The following is a description of a gene set: species: Homo sapiens Human Gene Set: GSE10239_MEMORY_VS_DAY4.5_EFF_CD8_TCELL_DN Genes down-regulated in comparison of memory CD8 T cells versus effector CD8 T cells. Using killer cell lectin-like receptor G1 as a marker to distinguish terminal effector cells from memory precursors, we found that despite their diverse cell fates both subsets possessed remarkably similar gene expression profiles and functioned as equally potent killer cells. However, only the memory precursors were capable of making IL-2 thus defining a novel effector cell that was cytotoxic, expressed granzyme B, and produced inflammatory cytokines in addition to IL-2. This effector population then differentiated into long-lived protective memory T cells capable of self-renewal and rapid re-call responses. Mechanistic studies showed that cells that continued to receive antigenic stimulation during the later stages of infection were more likely to become terminal effectors. Importantly, curtailing antigenic stimulation towards the tail-end of the acute infection enhanced the generation of memory cells. These studies support the decreasing potential model of memory differentiation and show that the duration of antigenic stimulation is a critical regulator of memory formation from publication Sarkar S, Kalia V, Haining WN, Konieczny BT, Subramaniam S, Ahmed R (PMID 18316415), and this is the list of marker genes: SET, ANKRD46, MARCHF5, KDM1B, YIPF5, PEX13, FARP1, MRPL44 (mitochondrial ribosomal protein L44), CASD1 (CAS1 domain containing 1), RRS1, DRAM2, LRBA, CSNK2A2, FAIM, ITPR1, RFC5, PRIM1, RPL23, MFF, DUSP4, PPM1H, SAP30, YTHDF2, TRIM59, SMARCC1, CTPS1, FLVCR1, AP3S1, CDK1, FDFT1, CDC16 (cell division cycle 16), XPO7, ACTR3, POGZ, MAPK9, DR1, BCL2L11, GSR, VKORC1L1, MORF4L2, DCUN1D5, MRPL39, NFYB (NCBI Gene Id 4801), KDSR, PRELID3B (PRELI domain containing 3B), BUB1B, C1GALT1, ERMARD, MEMO1, SSBP1, CRK, GTF2B, SLBP, GLRX3, WSB1, FEN1, NAA20 (N-alpha-acetyltransferase 20, NatB catalytic subunit), RPP30, METAP2, TCEANC, EAF1, PIGL, SLC39A6, CDCA5, MCM10, ASXL1, COPS5, GZMB, POU2AF1, AIFM1, ATL2, IBTK, CBX3, TAF3, SETD6, ALG10, IDH3A (NCBI Gene Id 3419), CYP20A1, SELENOI, VAPA, KCMF1, SLC35E2B, RFX5, KIF22, EED, GNA13, FRMD4B, HMGCR, NDUFAF5, TSTD2, HSD17B12, SLC25A4, CCDC34, FEM1B, LUC7L2, UBA2, SSR3, FBXW11, STRAP, SELENOH, NAA30, C1D, TP53BP1, GAPVD1, HARS1, RAPGEF2, TRA2B, NUDT5, MCM4, TUBB2A, SRSF10, CAND1, AP1S2, USP39, GINS2, OBI1, MCM2, SNRNP40, YAF2, SAV1, LDHA, GARS1, TAF5, KLHDC2, RSBN1, HMGCS1, UBP1, PRPF38A, LAMTOR3, USP42, ICOS, PRPS1, NARS1, EIF1AX, ZNF236, VAMP3, ZBTB14, PAFAH1B2, RBM7, MCM5, UFSP2, AHCYL2, RAB14, VMA21, PDLIM5, TYMS, GRSF1, PPP1R7, RPS2, TEX10, CDC7, DIDO1, TIAM1, AURKB, SRSF9, ZWILCH, ARFIP1 (ADP ribosylation factor interacting protein 1), ACTL6A, CCDC6, ALKBH5, THOC7, PAK2, IPO5, RRM1, E2F3, C1orf52 (chromosome 1 open reading frame 52), MSL3, SLC25A3, TNFRSF9, SLC7A1, HACD3, MLEC, MINDY3, GINS1, STRN, PSPC1 (NCBI Gene Id 55269), MAP3K1 (NCBI Gene Id 4214), CDC20, PLK4, SQLE, SC5D, RWDD4, MBTPS2, RAD23B (NCBI Gene Id 5887), NUP54, SLC33A1, PTCH1, CLCN3, ARF6, CDK17, QRSL1, EWSR1, OPA1, SPCS3, SNRPA1, AASDH, TM9SF2, PGK1, SLC25A13, TEX30